Given this list of marker genes DAG1 (NCBI Gene Id 1605), POMT1, POMT2, here is a description of the gene set: Co-expression of both protein O-mannosyl-transferases 1 and 2 (POMT1 and POMT2; CAZy family GT39) is necessary for enzyme activity, that is mediating the transfer of mannosyl residues to the hydroxyl group of serine or threonine residues of proteins such as alpha-dystroglycan (DAG1; MIM:128239). DAG1 is a cell surface protein that plays an important role in the assembly of the extracellular matrix in muscle, brain, and peripheral nerves by linking the basal lamina to cytoskeletal proteins. Defects in POMT2 (MIM:607439) results in defective glycosylation of DAG1 and can cause severe congenital muscular dystrophy dystroglycanopathies ranging from a severe type A, MDDGA2 (brain and eye abnormalities; MIM:613150), through a less severe type B, MDDGB2 (congenital form with mental retardation; MIM:613156) to a milder type C, MDDGC2 (limb girdle form; MIM:603158). part of: Diseases associated with O-glycosylation of proteins studied in species Homo sapiens Reactome Pathway: Defective POMT2 causes MDDGA2, MDDGB2 and MDDGC2